The following is a description of a gene set: Human Gene Set: GOBP_RESPONSE_TO_HERBICIDE Any process that results in a change in state or activity of a cell or an organism (in terms of movement, secretion, enzyme production, gene expression, etc.) as a result of a herbicide stimulus. Herbicides are chemicals used to kill or control the growth of plants. species: Homo sapiens, and this is the list of marker genes: HTRA2, CYP1A1, LCN2, ALAS1, ALAD